The following is a description of a gene set: species: Mus musculus Mouse Gene Set: REACTOME_INTRA_GOLGI_TRAFFIC Intra-Golgi traffic, and this is the list of marker genes: Gosr1, Cyth3, Cog6 (NCBI Gene Id 99791), Rab30, Alppl2, Rab36, Cyth1, Napb, Rab39, Nsf, Cog7, Bet1l, Cyth4, Vti1a, Gosr2 (golgi SNAP receptor complex member 2), Stx6, Ric1, Rgp1, Cog2, Cog5, Cog1, Cog4, Trip11, Ykt6, Cog3, Napg, Arf1, Cog8, Cyth2, Napa, Snap29 (NCBI Gene Id 67474), Rab33b, Stx16, Stx5a, Vps45, Alpi, Akp3